Given this list of marker genes Aadat, Dhtkd1, Dlst, Crym, Aldh7a1, Aass, Dld, Pipox, Hykk, Gcdh, Phykpl, Slc25a21, here is a description of the gene set: Mouse Gene Set: REACTOME_LYSINE_CATABOLISM Lysine catabolism species: Mus musculus